Given this list of marker genes TP53, USP36, OPTN, FBXW7, HDAC6, FBXO7, GBA1, BECN1, MAP1LC3B2, NIPSNAP3A, GSK3A, VPS13C, SPATA33, ATG9A, NIPSNAP3B, CTSK, SREBF2, NOD2, STUB1, RIMOC1, SLC25A4, ULK1, ATG5, FKBP8, ADCY10, MUL1, PHB2, UBE2A, BECN2, GABARAPL2, SREBF1, ATG7, DNM1L, MAP1LC3A, FZD5, EIF2S1, OGT, EIF2AK1, ARHGAP26, PPTC7, ATG9B, TIMM23, RBX1, MAP1LC3B, TSPO (translocator protein), VPS13D (NCBI Gene Id 55187), USP30, LRBA, GABARAPL1, NIPSNAP1, SNX30, AMBRA1, FUNDC1, GABARAPL3, PINK1, DELE1, CSNK2A2, CDC37 (cell division cycle 37, HSP90 cochaperone), TSC2, VDAC1, ATG4B, HTT, ULK3, ATG14, ATG4D, PARL, HK2, CLEC16A, RETREG1, MAP1LC3C, ATG4A, ABI2, TIGAR (TP53 induced glycolysis regulatory phosphatase), PRKN, ARFIP2, SNX7, CERS1, GABARAP, BNIP3, BNIP3L, SQSTM1, MFN2, BCL2L13, TOMM7, NIPSNAP2, IRGM (NCBI Gene Id 345611), FBXL4, RNF41, ATG4C, ATP5IF1, ULK2, HTRA2, CTTN, ATG10, HUWE1, SLC25A5 (solute carrier family 25 member 5), ATG13, here is a description of the gene set: studied in species Homo sapiens Human Gene Set: GOBP_MITOPHAGY The selective autophagy process in which a mitochondrion is degraded by macroautophagy.